The following is a description of a gene set: Human Gene Set: HP_FOCAL_HEMICLONIC_SEIZURE species: Homo sapiens Focal hemiclonic seizure A type of focal clonic seizure characterized by sustained rhythmic jerking rapidly involves one side of the body at seizure onset., and this is the list of marker genes: SCN1A, KCNH5, CUX2, SCN1B, SMARCAL1, GNB1 (G protein subunit beta 1), SLC12A5, TBC1D24, KCNT1, KCNQ2, COQ4, GABRA1 (NCBI Gene Id 2554), GRIN2A, GABRG2, SCN9A, KANSL1, PIGA, PCDH19, ATP1A3, SCN8A, SCN2A, FZR1, SLC25A22, FRRS1L, PLCB1, CACNA2D1